Given this list of marker genes BIRC5, UHRF1, TRIP13, KIF15, NCAPG2, CENPI, AKAP8L, FLNA, CCNB1, KATNB1, CHAMP1, CDC23, NSMCE2, KIF23, LSM14A, KIF2A, CHEK2, FBXO5, SMARCA5, XRCC3, NUF2, KNSTRN (NCBI Gene Id 90417), ZWINT, PRC1, ANAPC15, KMT5A, KIF3B, KIF4A, PSMG2, PSRC1, TTN, BUB1, NCAPH, CHMP4B, KPNB1, CHMP7, AURKC, CENPE, LCMT1, CDK5RAP2, PHF13, KIFC1, KNL1, SMC4, MIS12, KIF4B, OFD1 (OFD1 centriole and centriolar satellite protein), INO80, CDT1, PPP2R1A (NCBI Gene Id 5518), MAD2L1, BECN1, CHMP2A, SPAG5, SPC25, KAT5, SKA3, BCCIP, CHMP6, SEH1L (NCBI Gene Id 81929), APC, MAP10, RAD21, SPDL1, NUSAP1, TEX14, KIF18A, WAPL, DUSP1, NUP62, CDC16, ZWILCH, SIRT1, H2BW1, STAG2, ESPL1, IK, CHMP2B, UBE2C, TPR, SPC24, RACGAP1, DIS3L2, RAB11A, BUB3, CHMP1B, ABRAXAS2, POLDIP2, SMC1A, NCAPG, CHMP4BP1, NUMA1, INCENP, TUBG1, NCAPD3, USP44, KIF22, RANGRF, CHMP4A, NCAPD2, SKA2, RRS1, CCSAP, MISP, TPX2, MAD2L2 (NCBI Gene Id 10459), ANKRD53, CUL3, SPICE1, GEN1 (NCBI Gene Id 348654), KAT2B, CHMP5, PRICKLE1, KIF14 (kinesin family member 14), HASPIN, ANAPC7, MAD2L1BP, NEK2, NUDC, GOLGA2, RIPOR2, STAG1, RMDN1, ABRAXAS1, ZNF207, PRP4K, KIF18B, DRG1, BUB1B, SMC2, KIF25, KIF11, NDC80, NSL1, HSPA1A, VPS4A, CDCA5, PLK1, AAAS, MZT1 (mitotic spindle organizing protein 1), RHOA, CDC20, DCTN2, CENPC, PINX1, SMC3, PIBF1, MAPRE1, CENPF, BAZ1B, DYNC1LI1, MYBL2, ARHGEF10, PDCD6IP (NCBI Gene Id 245794), CHMP4C, ANAPC11, CHMP3, VPS4B, NCAPH2, HSPA1B, TENT4A, EML3, HNRNPU, PRAP1, CEP97, CEP192, MAP9, BOD1, KLHL22, CCDC66, CDK1, KIF2C, AKAP8, CLASP1, CENPK, TTK, RAN, CCDC61, RCC1, DLGAP5, ZW10, RB1, CLASP2, AURKB, NIPBL, CHMP1A, ANAPC5, SKA1, CDCA8, WRAP73, KNTC1, PPP1CC, MAD1L1, CEP55, ATM, EML4, TUBG2, here is a description of the gene set: The cell cycle process in which replicated homologous chromosomes are organized and then physically separated and apportioned to two sets during the mitotic cell cycle. Each replicated chromosome, composed of two sister chromatids, aligns at the cell equator, paired with its homologous partner. One homolog of each morphologic type goes into each of the resulting chromosome sets. species: Homo sapiens Human Gene Set: GOBP_MITOTIC_SISTER_CHROMATID_SEGREGATION